The following is a description of a gene set: studied in species Homo sapiens Human Gene Set: WP_METHIONINE_METABOLISM_LEADING_TO_SULFUR_AMINO_ACIDS_AND_RELATED_DISORDERS Methionine metabolism leading to sulfur amino acids and related disorders, and this is the list of marker genes: GNMT, CBS, AHCY, BHMT, CDO1, ADK, MAT1A, CSAD, MTR, MAT2B, CTH